Given this list of marker genes HEXB, CCL2, SCRIB, GPR183, NR2E1, CCR2, MMP14, APCDD1, CCL3, here is a description of the gene set: The orderly movement of an astrocyte, a class of large neuroglial (macroglial) cells in the central nervous system, the largest and most numerous neuroglial cells in the brain and spinal cord. Human Gene Set: GOBP_ASTROCYTE_CELL_MIGRATION species: Homo sapiens